The following is a description of a gene set: The presence of a hamartoma of the cerebrum. Cerebral hamartoma Human Gene Set: HP_CEREBRAL_HAMARTOMA species: Homo sapiens, and this is the list of marker genes: KIF7, TMEM231, TSC1, GCDH, SIX6, TSC2, IFNG, OFD1, MAN2C1, TOPORS, CPLANE1, TMEM216, VPS16, KIAA0753, SMO, SOX2, PDE6D, FAM149B1, TCTN3, GLI3, TIAM1